Given this list of marker genes EIF2S3, EIF2B2, EIF2B1, EIF2S2, EIF2S1, EIF2B3, EIF2B4, EIF2B5, here is a description of the gene set: species: Homo sapiens Human Gene Set: REACTOME_RECYCLING_OF_EIF2_GDP Recycling of eIF2:GDP